Given this list of marker genes DIPK2A, RHOQ, COPE, CNGB1, CLTB, CNGA4, NRGN, AP1S2, AFTPH, GJA1, TMEM199, TMED3, SYNRG, AP1G2, AP1M1, KDELR3, NCALD (neurocalcin delta), COPB2, AP1S3, CNGA2, COPG2 (NCBI Gene Id 80038), SPPL3, ARCN1, SPPL2A, COPZ1, SPPL2B, SLC18A3, PI4KA, ITM2B, AP1M2, ZDHHC13, CLTA, AP1S1, COPB1, COPA, CLTCL1, SCYL1 (NCBI Gene Id 57410), KDELR2, PKD1, AP4B1, TMED2, COPZ2, AP1B1, CLTC, GPR89A, TMED7, CLBA1, GOPC, ZDHHC17, CSPG5, AP1G1, CFTR, SPPL2C, AP2A1, COPG1, RHO, RASSF9, KDELR1 (KDEL endoplasmic reticulum protein retention receptor 1), here is a description of the gene set: The lipid bilayer surrounding a vesicle associated with the Golgi apparatus. species: Homo sapiens Human Gene Set: GOCC_GOLGI_ASSOCIATED_VESICLE_MEMBRANE